Given this list of marker genes Arf1, Soat2, Cideb, Mfsd2a, Ces1d, Fech, Soat1, Lpcat3, Acsl3, Dgat1, here is a description of the gene set: The non-covalent aggregation and arrangement of proteins and lipids in the liver to form a very-low-density lipoprotein particle. species: Mus musculus Mouse Gene Set: GOBP_VERY_LOW_DENSITY_LIPOPROTEIN_PARTICLE_ASSEMBLY